Given this list of marker genes SLC8A3, CHRNA3, SNCA, GRID1, GRIN2D, CHRNA5, RIMS1, PRKAR1B, ARRB2, AKT1, GABRB1, PRKN, RGS7, MET, GRIK4, MAPK8IP2, SLC8A2, ADRB1, NLGN1, CHRNB2, CELF4, WNT7A, GABRA4, STX1B, SEZ6, SLC17A7, SLC29A1, SSH1, NPY2R, P2RX7, SHANK1, ADORA2A, NLGN4X (neuroligin 4 X-linked), CUX2, GSK3B, MECP2, P2RX4, ATXN1, S1PR2, RELN, GABRA1, NPFF, GRIN3A, DRD4, GLRA1, TMEM25, RGS4, CHRNA9, GRIK2, KCND2, CHRFAM7A, GABRA2, GABRA6, GRIA4, NETO1, GRIN3B, MTMR2, GRIN2C, GHRL, BAIAP2, CHRNB4, BEGAIN, MPP2, SHANK3, TBC1D24, CDK5, CHRNG, ZMYND8, DRD2, GABRA3, GABRR2, HTR3E, CBLN1, CHRNA7, GLRB, HCN1, P2RX3, CHRM1, GRIK3, HCRT, NLGN3, EIF4A3, GRIA2, CHRNA2, HTR3B, ABAT, APP, PTK2B, NOS1, DVL1, CHRNB1, GABBR1, PRKCZ, ADORA1, HTR3C, DLG4 (discs large MAGUK scaffold protein 4), NPAS4, GRIN2B, GABRA5, RAB3GAP1, PPP3CA, GABRB2, GABRB3, CHRNA4, GRIK5, GRID2, NRXN1, P2RX6, NLGN2, TMEM108, KCNK1, P2RX1, SLC1A7, GSK3A, P2RX5 (NCBI Gene Id 5026), CHRND, INSYN2A, GRIA3, ADRB2, HTR3A, INSYN1, GLRA3, PTEN, RIMS2 (regulating synaptic membrane exocytosis 2), GRM5, HTR3D, MIR30B, CHRNA10 (cholinergic receptor nicotinic alpha 10 subunit), GABRG3, DMPK, KCTD16, GABRG2, CHRNE, GRIN1, LRRK2, RGS7BP, NTSR1, CHRNB3, KCNA2, GABRD, GRIK1, CHRNA1, UNC13B, STX1A, GRIA1, GRIN2A, MEF2C, GRM1, TRPV1, CHRNA6, GLRA2, P2RX2, here is a description of the gene set: species: Homo sapiens Human Gene Set: GOBP_REGULATION_OF_POSTSYNAPTIC_MEMBRANE_POTENTIAL Any process that modulates the potential difference across a post-synaptic membrane.